The following is a description of a gene set: Mouse Gene Set: GOBP_ASYMMETRIC_NEUROBLAST_DIVISION species: Mus musculus The process resulting in the physical partitioning and separation of a neuroblast into two daughter cells with different developmental potentials., and this is the list of marker genes: Fgf13, Sox5, Tead3, Arhgef2, Rab10, Dock7